Given this list of marker genes DNMBP, UBE2V1, SEH1L, RHD, BTBD6 (BTB domain containing 6), C5orf24, DIPK2A, SLC2A9, GLP1R, SH3PXD2B, SFN, GSTM3, MTUS1, LCMT2, AKAP3, ADAM28, ITGA5, MPZL2, MFSD6, CDK18, TBPL1, DCBLD2, ALG2, BEND4, POLR2M, SEZ6L2, ELMOD3, MID1IP1, FNBP1, NEDD4L, PCGF6, GABRA3, ST7, SLC2A6, ZBTB37, PSMD1, TTC7B, EHHADH, GPN2, C3orf70, SPRYD7, TSG101 (NCBI Gene Id 89764), SLF2, INSIG2, STXBP1, SLC38A1, IL21R, JAG1, PCBP2, SHB, SLAIN2, OVCA2, SLC30A4, STEAP4, VWA8, GDF10, CXCR3, CYP3A7, KIF12, RETREG1, EDNRB, KDSR, PTGIR, CAMKK1, ARHGAP26, PCDHB16, GUSB, RNF14, ETS1, UBE2J1, RPS6KA2, SPA17, SLC25A23, APP, ST14, CYYR1, ZFPM1, IL1RN, MKRN2, TRIM21, SPZ1, NFATC2, MAGEE1, CLPTM1, MSR1, TENT5C, MYH10, PANX1, PYGB (glycogen phosphorylase B), LRRC28, TIAM1, SPIRE1, FAM78A, BCAP29, BCL7C, CD34, ZMAT3, OPRM1, TUBG2 (tubulin gamma 2), CBX2, KANSL1, KPNA4 (karyopherin subunit alpha 4), B4GALT4, CD276, FAT3, TAF3, VAV3, CDK6, SYT11, DNAAF5, SLC25A12, F13B (NCBI Gene Id 2165, coagulation factor XIII B chain), PRKG1, KPNA3, ORC2, CEP104, UTP4, VMA21, RCAN1, TAOK2, PABPC1, LRRC14, GASK1B, PKP3, ADGRL1, MMP13, UBE2D3, MDM2, ITGAL, BTBD3, SPRR3, PRR5L, SAP30, PTGS1, CABLES2 (Cdk5 and Abl enzyme substrate 2), PIP4K2B, SFMBT1, LMLN, PGM2, SPTB, AK1, TBL1X, CD1D, ST8SIA3, MARCKSL1, TGM1, CD99L2, RAB34, LYZL6, ZNF438, ACTR1B, ABI2, RHOH, MMP12, C1orf53, AKTIP, ERAP1, RAP2A, PTPRA, HOXB2, PHETA1, PLEK, NCAPG2, ITPRID2, ADGRG6, RAPGEF5, LAIR1, RAB11A, MAN1A1, TMED8, LANCL2, TAS1R2, SH3D19, STAMBPL1, CCDC120, RIOX1, RPL31, WTAP, DYNC2I2, ASIC3, PPTC7, TMX4, ICA1L, APBB1IP, RRP8, ESD, CCAR2, SEMA4C, NLRC3, TRAK2, RNGTT, UBASH3B, BRF1, WTIP, SPX (spexin hormone), THAP12, EXOC6B, ACOT11, ZCCHC3, MRM3, here is a description of the gene set: Genes down-regulated in bone marrow-derived macrophages with IL10 knockout and 45 min of stimulation by: LPS versus IL6 and LPS. Human Gene Set: GSE5589_LPS_AND_IL10_VS_LPS_AND_IL6_STIM_IL10_KO_MACROPHAGE_45MIN_DN IL-10 or IL-6 stimulation of control 129xC57BL/6 murine bone marrow derived macrophages in the presence of LPS. We used microarrays to detail the global programme of gene expression changes in response to IL-6 or IL-10 stimulation in the presence of lipopolysaccharide. BMDMs were isolated from control, IL-6-/-, and IL-10-/- mice on a 129XBL/6 mixed background mice and differentiated in the presence of CSF-1 for 6-7 days. Cells were scraped and plated in 6 well plates at 2x10e6/well. Cells were washed with complete DMEM and rested for 1-2 hr before stimulation with combinations of IL-10 (10 ng/ml), IL-6 (2 ng/ml) or LPS (100 ng/ml) for 45 min or 180 mins. Complete biological replicates were performed. species: Homo sapiens from publication El Kasmi KC, Holst J, Coffre M, Mielke L, de Pauw A, Lhocine N, Smith AM, Rutschman R, Kaushal D, Shen Y, Suda T, Donnelly RP, Myers MG Jr, Alexander W, Vignali DA, Watowich SS, Ernst M, Hilton DJ, Murray PJ (PMID 17114459)